Given this list of marker genes SLK, CMAS, ADORA2A, PPP3CC, PPP2R5D, GNPDA1, MYO1F, GEM, CMC2, NECAP2, MT1E, STX5 (syntaxin 5), IL18R1, YIPF4, SUN2, EXOC7, FGF19, ARHGDIB, ADD1, BATF (basic leucine zipper ATF-like transcription factor), HGSNAT, XPR1, S100A6, FTH1, KLRD1, GADD45G, PRDM1, ACTG1 (NCBI Gene Id 71), TUBA3C, STX7, COX7B, EMB, SELP, TPGS2, CYTIP, MT2A, ENTREP3, PGAM1, PCMT1, ALDH7A1, PQBP1, UBE2L3 (ubiquitin conjugating enzyme E2 L3), CDCA7L, TACSTD2, ACLY, PJA1, CBX6 (NCBI Gene Id 23466), GPAT4 (glycerol-3-phosphate acyltransferase 4), GCNT1, TAGLN2, JARID2, KIT, CCR2, STAT5A, FBN2, CDADC1, BTBD1, JUND, CNDP2, PLPBP, IRX3, SOX11, CD38, GNB5, SPATS2, RAC2, HDLBP, CTSD, TNFSF10, ARL4C, TAX1BP1, CSTB, GMFG, SQOR, FLOT1, ASIP, ABHD8, ADRB2, KL, SELL, NEDD4, S100A4, AHR, ST3GAL2, SSR3, LHX9, LGALS3 (galectin 3), LTB, SLC27A2, DAP (NCBI Gene Id 1611), NEDD4L, ECHS1, RBPJ, ERCC4, H2AX, LDAF1, JAK3, AHNAK, MATK, CSDE1, FURIN, ACSL1 (acyl-CoA synthetase long chain family member 1), JUN, OAT, LDHA, SMPD1, PTPRK, SSRP1, BCL3, KHDRBS1, DGAT1, ANXA2, MRPL48, IFNG, AHCY, CAST, IL1RL1, ALCAM, S100PBP, PLEKHA5, ARF1, PRNP, SERBP1, EHD1, ZMAT3, CDS2, ONECUT1, GSN, THPO, PLD3, DBP, NID2, RPP21, GABARAPL1, KLF7, PLS3, ATP6V0A2, CCR5, S100A10, DSTN, ALAD, P2RX4, UBE2H, TULP4, PLA2G12A, NDFIP2, RNH1, S100A1, TWIST1, CYB5A, PRR5, SKAP2, CRABP2, IL1R1, GPI, IL6ST, CCND3, DIAPH3, MED12L, USP9X, CHD7, TWF2 (NCBI Gene Id 11344), E2F8, OAZ2, DPM2, ARMCX2, CASP6, KIFAP3, THY1, RRAD, EMP1, FAM107B, GTF2I, MMP10, FAM89B, SERPINB5, PTPN22, GIMAP4, LPP-AS2, AKT2, MT3, MYD88, SIRT2, SIRT3, CTSE, B3GALNT2, NUDT16L1, AURKA, S100A11, FGGY, ANKRD28, GCSAM, NKAIN1, DYNLL2, SATB1, SPOP, SMIM14, PDZK1IP1, DDX17, RPL12, here is a description of the gene set: Human Gene Set: GSE15930_STIM_VS_STIM_AND_TRICHOSTATINA_48H_CD8_T_CELL_UP studied in species Homo sapiens from publication Agarwal P, Raghavan A, Nandiwada SL, Curtsinger JM, Bohjanen PR, Mueller DL, Mescher MF (PMID 19592655) Differentiation of naive CD8 T cells into cytotoxic effector cells requires three distinct signals- antigen (signal 1), costimulation -B7-1 (signal 2) and cytokine, either interleukin-12 or interferon-a/b (signal 3). Interaction of naive CD8 T cells with antigen and B7-1 programs cell division and proliferation whereas the presence of cytokines- IL-12 or IFNa/b promote survival, differentiation and memory establishment. In the absence of signal 3, the cells interacting with antigen/B7-1 undergo tolerance induction. The objective of this study was to elucidate the mechanisms how the provision of signal 3 promotes differentiation and averts tolerance induction in CD8 T cells. Trichostatin A is a pharmacological agent that inhibits histone deacetylase activity, hence regulating chromatin structure and gene expression and differentiation in many cell types. Gene signature profiles of IL-12, IFNa/b and trichostatin A stimulated cells were compared to elucidate the molecular mechanisms of gene regulation. Oligonucleotide microarray analysis is carried out to determine the extent and molecular nature of the CD8 T cell differentiation program induced by IL-12 or IFNa/b in concert with antigen and B7-1 signal. Genes up-regulated in comparison of unstimulated CD8 T cells at 48 h versus CD8 T cells at 48 h after treatment with trichostatin A (TSA).